Given this list of marker genes IRAK1, RAD51, IRF2BP2, SASH3, TBL1XR1, DDX41, RPL27, RAD51C, ERCC6L2, IRF1, RPS14, SAT1, FCGR2B, NPM1, PRF1, ZBTB16, RTEL1, FANCG, GALE, CA2, RBPJ (recombination signal binding protein for immunoglobulin kappa J region), ERCC4, BLOC1S6, USB1, TNFAIP3, TERC, TNIP1, FOCAD, IRF5, ARHGAP31, SEC61A1, FANCI, FANCD2, RARA, FIP1L1, SLX4, VPS13B, OTUD5, BTNL2, TINF2, MMUT, RPS29, IL10, IVD, MYSM1, TREX1, GBA1, XRCC2, EOGT, RPS17, RPS24, SARS2, FCGR2A, BLK (BLK proto-oncogene, Src family tyrosine kinase), NABP1, PML, RPL8, C1GALT1C1, STAT3, SPP1, DOCK6, DKC1, RPL11, JAZF1, SLF2, NOTCH1, RPS26, FANCL, IGHG1, CR2, HLA-DRB1, RPS28, ETS1, RFWD3, NOP10, RAP1B, TSR2, VPS45, BCOR, PXK, EPG5, FANCC, UBE2T, SLC7A7, EFL1, BRCA2, MAP2K1, ADH5, FANCE, PRKAR1A, BRIP1, RPL15, ATP6AP1, UROS, PIGA, TRNT1, NRAS, PGM3, UBE2L3, ITGAM (NCBI Gene Id 3684), TBXAS1, FCGR3B, STING1 (NCBI Gene Id 340061), SLC46A1, C4A, ITK, LYST, TERT, RPL5, FANCA, FANCM, NUMA1, TNFSF4, HMGCL, ZNF699, RAC2 (NCBI Gene Id 5880), PALB2, RPL18, BANK1, TLR7, DNASE1, SCARB2, PDCD1, VPS33A, DNAJC21, SBDS, RPS15A, ADA2, HEATR3, CTLA4, KIAA0319L, RPS10, SAMD9, ISCU, RPS19 (ribosomal protein S19), RPL35, TGFB1, RPS7, RPL9, BRAF, RPL31, PTPN22, FANCB, C4B, BRCA1, GATA1, DLL4, RPL35A, RPS27, RPL26, STAT5B, AK2 (adenylate kinase 2), LIPA, G6PC3, STAT4, MAD2L2, FANCF, MECP2, NAE1, RPS20, CLPB, here is a description of the gene set: Human Gene Set: HP_DECREASED_TOTAL_LEUKOCYTE_COUNT An abnormal decreased number of leukocytes in the blood. species: Homo sapiens Decreased total leukocyte count